Given this list of marker genes Bdp1, Polr2e (NCBI Gene Id 66420), Crcp, Gtf3c2, Gtf3c5, Gtf3c6, Polr3c, Gtf3c1, Polr2f (polymerase (RNA) II (DNA directed) polypeptide F), Polr3f, Gtf3c3, Polr3g, Polr2h, Polr3e (NCBI Gene Id 26939), Polr3h, Polr3gl, Polr3k, Polr2l, Polr1c, Gtf3c4, Tbp, Polr3a (NCBI Gene Id 77514), Polr3b, Brf1, Polr3d, Gtf3a, Polr2k, here is a description of the gene set: studied in species Mus musculus RNA Polymerase III Transcription Initiation From Type 1 Promoter Mouse Gene Set: REACTOME_RNA_POLYMERASE_III_TRANSCRIPTION_INITIATION_FROM_TYPE_1_PROMOTER